The following is a description of a gene set: Mouse Gene Set: GOBP_MATURE_B_CELL_DIFFERENTIATION_INVOLVED_IN_IMMUNE_RESPONSE The process in which a naive B cell acquires the specialized features of a mature or memory B cell during an immune response. species: Mus musculus, and this is the list of marker genes: Nfkbiz (NCBI Gene Id 80859), Lgals1, Dock10, Plcg2, Gpr183, Lilrb4a, Itm2a, St3gal1, Phf14, Ptk2b, Muc19, Il10, Spi1, Mfng, Notch2, Xbp1, Bcl6, Enpp1, Nkx2-3, Dock11, 6030468B19Rik, Ada, Il6, Itfg2, Pou2af1, Il2, Lgals8, Cdh17, Irf8, Bcl3, Dll1, Tnfaip3, Ddrgk1, Lfng, Rag2, Il21